The following is a description of a gene set: The process in which the migration of an axon growth cone of a commissural neuron is directed to its target in the brain in response to a combination of attractive and repulsive cues. Mouse Gene Set: GOBP_COMMISSURAL_NEURON_AXON_GUIDANCE species: Mus musculus, and this is the list of marker genes: Adam17, Nell2, Vegfa, Fzd3, Gdnf, Dag1, Ephb2, Robo3, Nfib, Smo, Ncam1, Ptch1, Nrp1, Ryk, Shh